The following is a description of a gene set: species: Homo sapiens Altered immune function characterized by lymphoid proliferation, immune activation, and excessive autoreactivity often leading to autoimmune/inflammatory complications. Human Gene Set: HP_IMMUNE_DYSREGULATION Immune dysregulation, and this is the list of marker genes: STX11, UNC13D, PDCD1, ACP5, LEPR, LAT, STXBP2, PLCG2, PRF1, STAT1, FOXP3